The following is a description of a gene set: species: Mus musculus Any process in which a protein is transported to, or maintained at, the centromeric region of a chromosome. Mouse Gene Set: GOBP_PROTEIN_LOCALIZATION_TO_CHROMOSOME_CENTROMERIC_REGION, and this is the list of marker genes: Champ1, Knl1, Zwilch, H2ac4, Haspin, Cdk1, Mis18a, Snhg15, Bub1b, Kntc1, Aurkb, Rcc2, Ik, Bub3, Zw10, Mtbp, Cenpq (NCBI Gene Id 83815), Jarid2, Rb1, Cenpa, Smc5, Trappc12, Ctcf, Spdl1, Ttk